The following is a description of a gene set: Multiple small zones of sarcomeric disorganization and lack of oxidative activity (known as minicores) in muscle fibers. Human Gene Set: HP_MINICORE_MYOPATHY species: Homo sapiens Minicore myopathy, and this is the list of marker genes: MYH7, CFL2, MEGF10, TNNT1, FXR1 (FMR1 autosomal homolog 1), TTN, TRIP4, SELENON, RYR1